Given this list of marker genes Gpr39, Atp6v0c, Cnr1, Ncs1, Ifnb1, Car7, P2rx2, Cx3cl1, Hexb, Atp6v1c1, Tmem106b, Atp6v1d, Calb1, Cacnb2, Cacna1a, Slc8a2, Adora1, Tspoap1, Fggy, Tyro3, Immt, Nell2, Rimbp2, Atp6v1g3, Slc17a7, Chrna1, Psen1 (presenilin 1), Aim2, Map1a, Erc2 (ELKS/RAB6-interacting/CAST family member 2), App, Mink1, Marcksl1, Clcn3, Atp6v1b2, Grin1, Slc24a2, Chmp2b, Atp6ap2, Npy1r, Psen2, Taok1, Cacna1d, Prkn, Sv2b, Cdk5, P2ry2, Atp6v0e2, Snapin, Calb2, Atp2a2 (NCBI Gene Id 319250), Atp6v1b1, Atp7a, Atp6v1a, P2ry1, Npy, P2rx1, Atp6v1g2, Disc1, Atp6v1f, Erc1, Haao, Tsc22d4, Atp6v1e1, Cacnb4, Atp6ap1, Prkaa1, Car2, Atp6v0a1, Kcnh1, Osbpl2, Atp6v0a4, Dctn1, Atp6v1h, Atp6v0d1, P2ry4 (pyrimidinergic receptor P2Y, G-protein coupled, 4), Atp2b2, Htr1b, Bap1, Slc9a6, Atp6v1g1, Tmem175, here is a description of the gene set: The cellular homeostatic process that preserves a neuron in a stable, differentiated functional and structural state. Mouse Gene Set: GOBP_NEURON_CELLULAR_HOMEOSTASIS studied in species Mus musculus